Given this list of marker genes GRHPR, ALG9, PKD1, SLC34A2, ALG5, ADCY10, PKD2, AGXT, SLC26A1, BICC1, TBC1D7, SLC34A3, GANAB, IFT140, OPLAH, DNAJB11, SLC36A2, HOGA1, here is a description of the gene set: species: Homo sapiens Human Gene Set: HP_CALCIUM_NEPHROLITHIASIS Calcium nephrolithiasis The presence of calcium-containing calculi (stones) in the kidneys.